Given this list of marker genes Neat1, Stk17b, Cox7a2l, Herc6, Mycbp2, Ccl9, Ifi203, Ssh2, Nfkbia, Clec12a, Crlf3, Pirb, Niban1, Pmaip1, Junb, Npc2, Tlr13, Stap1, Gpr141, Trps1, Tsc22d3, Laptm5, Cd47, Arl5c, Mcl1, Cybb (NCBI Gene Id 97621), Fth1 (ferritin heavy polypeptide 1), Eef2, Ms4a6b, Ptprc, Klf6, Rgs2, Hspa1b, Zfp36, Ier2, Lyz2, Ptgs2, St8sia6, Dusp1, Pdcd4, H2az1, Clec4b1, Stom, Tgfbi, Igsf6, Marveld1, Klhl24, Ccrl2, Smpdl3a, Ypel3, Abca9, Adgre4, Foxp1, Zeb2, Jun, Il13ra1, Ramp1, Btg1, Pik3cg, Tpd52, Mcemp1, Fos (NCBI Gene Id 14281), Il1b, Itga4, Emb, Hspa1a, here is a description of the gene set: from publication Cui A, Huang T, Li S, Ma A, Pérez JL, Sander C, Keskin DB, Wu CJ, Fraenkel E, Hacohen N (PMID 38057668) studied in species Mus musculus Cytokines mediate cell-cell communication in the immune system and represent important therapeutic targets. A myriad of studies have highlighted their central role in immune function, yet we lack a global view of the cellular responses of each immune cell type to each cytokine. To address this gap, the authors created the Immune Dictionary, a compendium of single-cell transcriptomic profiles of more than 17 immune cell types in response to each of 86 cytokines (>1,400 cytokine-cell type combinations) in mouse lymph nodes in vivo. A cytokine-centric view of the dictionary revealed that most cytokines induce highly cell-type-specific responses. For example, the inflammatory cytokine interleukin-1β induces distinct gene programmes in almost every cell type. A cell-type-centric view of the dictionary identified more than 66 cytokine-driven cellular polarization states across immune cell types, including previously uncharacterized states such as an interleukin-18-induced polyfunctional natural killer cell state. Mouse Gene Set: CUI_CDC2_IL13_RESPONSE_DN Genes negatively differentially expressed in cell type: cDC2 (conventional dendritic cell type 2) upon treatment with cytokine: IL-13 in mouse lymph nodes in vivo.